The following is a description of a gene set: Neighborhood of UBE2N ubiquitin-conjugating enzyme E2N (UBC13 homolog, yeast) in the GCM expression compendium Human Gene Set: GCM_UBE2N Neighborhood of UBE2N studied in species Homo sapiens, and this is the list of marker genes: KAT6B, MED13, UBE2N, BTRC, USP33, ACBD6 (acyl-CoA binding domain containing 6), CAND1, FAM168B, TMEM183A, EXOSC6, GSK3B, ARL6IP1 (NCBI Gene Id 56166), LEMD3, CLEC16A, PKNOX1, RBM4B, PHF2, NCOA5, CCDC82, DCTN4, YTHDC1, PTBP2 (polypyrimidine tract binding protein 2), MOAP1, EPC2, SPAST, MARCHF6, PHF10, RSBN1, KMT2A (NCBI Gene Id 79951), MFAP3, HIPK1, PPM1B, HNRNPR, EXOC5, NSD2, SMC3, NFIB, MECP2, NAA30, SLC25A29, ZFAND5, RAN, UBE2K, KAT7, ZNF384, NCAM1, ISCA1, ASTN2, PPIG, CSRNP2, EPM2AIP1, CEP170, ZFTA, COMMD9, SLC35E2A, PGRMC2 (NCBI Gene Id 10424), C2CD5, SUFU, MTMR3, SAP130, HNRNPH3, ZNF84, ADNP, DLG3, IPO9, BPTF, GTF3C4, VPS52, SS18L1, FN3KRP, PAFAH1B2, VDAC3, CIPC, UBE2E3 (NCBI Gene Id 10477), RBFOX2, CHD9, GPALPP1, FBXO30, CHTOP, WBP11 (WW domain binding protein 11), TARDBP, CELF1, UBR7, RABGEF1, TRAPPC14, ELP1, MSL1, DYNC1I2, WBP2, UPF3A, VEZF1, RALGAPA1, ZNF273, BSDC1, EIF4ENIF1, NLK, REPS1, APBB3, ARID1A, TIA1, IDH3G, SMAD2, NAB1, ZXDB, CREB1, AAAS, RANBP6, DHX40, PRKRA, BRPF3, SYNC, FBXO3, FOXO3, DCAF7, ZNF566, TUBGCP4, ZNF292, CXXC5, POGZ, CDIPT, LUC7L3, CRNKL1, TADA1, TSPYL4, AHDC1, ZMYM2, TRIM33 (tripartite motif containing 33), CIZ1, YME1L1, ABHD16A, RABL2B, USP19, NF2, TUBGCP3, CNOT6 (CCR4-NOT transcription complex subunit 6), WSB2, NAA25, ZMIZ1, NGRN, ZNF529, IQCK, VPS26B, HECTD1, NUDT4 (NCBI Gene Id 57236), BAZ2A, KLHL11, PRRC2B, CS, NFYA, RNF41 (ring finger protein 41), MED17, KIDINS220, RBM8A, DHX36